The following is a description of a gene set: Human Gene Set: GOBP_LEUKOCYTE_ADHESION_TO_ARTERIAL_ENDOTHELIAL_CELL species: Homo sapiens The attachment of a leukocyte to an arterial endothelial cell via adhesion molecules., and this is the list of marker genes: MIR92A1, TNF, SLC39A8, ZDHHC21, KLF4, ALOX5